The following is a description of a gene set: Human Gene Set: GAUTAM_EYE_CORNEA_MONOCYTES Occular cell types curated from Gautam and Hamashima et al. Multi-species single-cell transcriptomic analysis of ocular compartment regulons species: Homo sapiens from publication Gautam P, Hamashima K, Chen Y, Zeng Y, Makovoz B, Parikh BH, Lee HY, Lau KA, Su X, Wong RCB, Chan WK, Li H, Blenkinsop TA, Loh YH (PMID 34584087), and this is the list of marker genes: POLR3E, FYB1, IL4R, FBRSL1, SRC, VPS11, FBXO30, ZNF260, CHST7, ATP13A3-DT, SNX18, ADGRE5, TMEM127, F8A1, HDAC9, THAP2, RARA, PPWD1, DOP1B, DNAJC5, COMMD5, LBR, JPT1, MOAP1, MYO1D, ZNF726, ETV5, PLEKHA7, TIMM29, PCYT1A, P4HA1, AGPAT1, RBM39, MARCHF7, NQO2, ZBTB46, OPHN1, RIC1, METTL14, DGAT1, ATP11B, ZNG1A, KIF2A, SLC4A1AP, BAK1 (NCBI Gene Id 578), PGAP6, ACSL6, LIPT1, MTMR6, RPS19, GALC, ALKBH7, CTSA, PRXL2B, TGFBR2, SMCHD1, SCAMP3 (secretory carrier membrane protein 3), ATP6V1C1 (ATPase H+ transporting V1 subunit C1), RPN1, DCAF16, PHF19, ACSL4, ATG14, IL18BP (NCBI Gene Id 10068), UPF2, HNRNPA1L2, PLA1A, C19orf25, GPR3, SDHB, MCRS1, DENND5A, PLB1, FAM131A, CTDSP1, WBP1L, RNF19B, GADD45G (NCBI Gene Id 23575), NAF1 (NCBI Gene Id 92345), FBXW5, MLF2, NFATC1, KCTD17, PIGA, LINC01003 (NCBI Gene Id 100134539), NUDT22, NUMB, ITCH, ANKRD9 (NCBI Gene Id 122416), TFEB, ZNF224, UNC13D, ZSWIM7 (NCBI Gene Id 125150), GALNT6, ATM, RRP9, MAP4K1, SDSL, VSIR, TRIP11, ZNF75A, ATP5F1B, SLC39A10, ZNF317, GIMAP7, TENT2, CDK17, PCBP1-AS1, IL17RC, CLIC4, SLC46A3, FGD3, GRINA, POU2F1, ASXL2, CNEP1R1, APAF1, ELOC, TTL, SLBP, FKBP3, PLAC8, MINPP1, ALYREF, TOR2A, SLC9A9, POLR3A, KIF1B, SEMA4A, DDX10, SIK3, NUDT1, SULT1A1 (sulfotransferase family 1A member 1), CNOT1, PLEKHO2, ABHD12, IL16, CPSF1, DEF8, HPS3, PHTF2, ZNF532, CCNK, GNG7, SLC22A18, C19orf38, PRCP, KDM2B, HM13, LYSMD3, RLF, SUSD3, SLC35B2, GALNT2 (NCBI Gene Id 2590), WDR11, EZH2, ARAP1, ZMYM5 (NCBI Gene Id 9205), FPGS, SEPTIN2, MLXIP, CREBBP, MARF1, ARHGAP6, DMXL1, SAFB2, PLA2G15, MCOLN2, SPATA13, MAMLD1, ARHGEF5, PPARD, TCN2, FAM168A, PLXNA3, CLPX, RUBCN, CBARP, PCNX2, VPS18, SPTY2D1, BRAF, GNL2, ZNF710, RPE, ZYX, VAV1, TENT5A, ORMDL2, ATF6B, MMD, YIF1B, TMEM208, WIPI1, KLF7, GTF2A1, ZNF197, DRAM1, EMB, NOL4L, NMI, NIBAN1, CCDC117, CCDC85B, H2AX, MED6 (NCBI Gene Id 10001), UNC119, PCGF5, MAPKAPK3, NEK6, DEF6, MAPKAPK5, DCTN4, BCL2L11, THEM4, RPLP2, TK1, MAP1LC3B2, MRPS30, ADCK2, P3H2, SNAI3, SLC35E1, RAI1, KMO, WDR55, RAP2C, PILRB, SEMA7A, EEF1AKMT2, THBS2, DNAJB9, MED8, ABHD15, MBOAT7 (membrane bound O-acyltransferase domain containing 7), ZNF140, ZNF579, RABL6, TMEM199, SCD, BORCS5, MYO15B, MYD88, ACKR3, SH2B2, MAML1, PLEKHJ1, FERMT3, ARID3B, CHML, GPATCH11, RANGRF, LY9, YTHDC2, NKAP, CSF1